Given this list of marker genes Nup37, Nup160, Pias2, Smc6, Blm, Ube2i, Nsmce4a, Sumo2, Nup188, Rnf168, Cbx2, Ndc1, Pias1 (NCBI Gene Id 72966), Tpr, Hdac7, Bmi1, Phc1, Nup54, Nup210, Rad21, Parp1, Nsmce1, Aaas, Mdc1, Pcgf2, Nup155, Eid3, Cbx4, Nup93 (nucleoporin 93), Nup50, Rad52, Rae1, Smc1a, Herc2, Nup58, Sumo3, Nup98, Stag2, Sec13, Nup107, Rnf2, Seh1l, Nup153, Nup42, Rpa1, Nup35, Smc3, Cbx8, Pml, Nup85, Phc3, Brca1, Cetn2, Nup43, Stag1, Sp100, Phc2, Nup88 (nucleoporin 88), Nsmce2, Nup133, Nup205, Xpc, Xrcc4, Sumo1, Nsmce3, Smc5, Nup62, Pias4, Scmh1, Tdg, Nup214, Ring1, Pom121, Ranbp2, here is a description of the gene set: SUMOylation of DNA damage response and repair proteins Mouse Gene Set: REACTOME_SUMOYLATION_OF_DNA_DAMAGE_RESPONSE_AND_REPAIR_PROTEINS studied in species Mus musculus